Given this list of marker genes Crtc2, Sik1, Crebbp, Atf2, Ddit3, Crtc3, Creb3, Icmt, Atf4, Crtc1, here is a description of the gene set: Binding to a cAMP response element binding protein (a CREB protein). species: Mus musculus Mouse Gene Set: GOMF_CAMP_RESPONSE_ELEMENT_BINDING_PROTEIN_BINDING